Given this list of marker genes PPA1, LHPP, PPA2, here is a description of the gene set: Many biosynthetic reactions are coupled to the cleavage of ATP to yield AMP and pyrophosphate. These reactions are typically freely reversible when carried out with purified substrates and enzymes in vitro. In vivo, however, the pyrophosphate is rapdily and essentially irreversibly hydrolyzed by a ubiquitous inorganic pyrophosphatase. This hydrolysis has the effect of pulling the first reaction strongly in the direction of biosynthesis, at the expense of two high-energy phosphate bonds. Studies of human cells have identified two forms of the enzyme, one localized to the cytosol and the other to the mitochondrial matrix.<br>Pyrophosphatase activity has likewise been shown for LHPP (Phospholysine phosphohistidine inorganic pyrophosphate phosphatase). Reactome Pathway: Pyrophosphate hydrolysis part of: Metabolism species: Homo sapiens